Given this list of marker genes Hadhb, Gcdh, Ehhadh, Eci2, Acaa1b, Acadl (NCBI Gene Id 98523), Pex7, Acads, Acoxl, Irs2, Cpt1b, Obp2a, Mtor, Etfbkmt, Cpt1a, Abcd3, Abcd4, Acox2, Cpt2, Acaa1a, Ech1, Hsd17b10, Abcd2, Etfb, Acadm, Lonp2, Mlycd, Pex2, Twist1, Crat, Irs1, Acat1, Abcd1, Etfa, Fabp1, Acsbg2, Akt1, Acaa2, Acox3, Hadha, Bdh2, Hsd17b4, Dbi, Slc25a17, Crot, Hadh, Abcb11, Lep, Acacb, Mfsd2a, Echs1, Pex5, Cnr1, Acox1, Ppard, Decr1, Acad10 (NCBI Gene Id 71985), Eci1, Echdc1, Auh, Acadvl, Acad11, Adipoq, Sesn2, Acad12, Ivd (NCBI Gene Id 98988), Aldh1l2, Mtln, Plin5 (perilipin 5), Scp2, Acsl5, Echdc2, Etfdh, Slc27a2, Akt2, Eci3, Tysnd1, here is a description of the gene set: Mouse Gene Set: GOBP_FATTY_ACID_BETA_OXIDATION A fatty acid oxidation process that results in the complete oxidation of a long-chain fatty acid. Fatty acid beta-oxidation begins with the addition of coenzyme A to a fatty acid, and occurs by successive cycles of reactions during each of which the fatty acid is shortened by a two-carbon fragment removed as acetyl coenzyme A; the cycle continues until only two or three carbons remain (as acetyl-CoA or propionyl-CoA respectively). species: Mus musculus